The following is a description of a gene set: Human Gene Set: GSE19198_1H_VS_24H_IL21_TREATED_TCELL_DN from publication Kwon H, Thierry-Mieg D, Thierry-Mieg J, Kim HP, Oh J, Tunyaplin C, Carotta S, Donovan CE, Goldman ML, Tailor P, Ozato K, Levy DE, Nutt SL, Calame K, Leonard WJ (PMID 20064451) Interleukin-21 (IL-21) is a pleiotropic cytokine that induces expression of transcription factor BLIMP1 (encoded by Prdm1), which regulates plasma cell differentiation and T cell homeostasis. We identified an IL-21 response element downstream of Prdm1 that binds the transcription factors STAT3 and IRF4, which are required for optimal Prdm1 expression. Genome-wide ChIP-Seq mapping of STAT3- and IRF4-binding sites showed that most regions with IL-21-induced STAT3 binding also bound IRF4 in vivo, and furthermore, revealed that the noncanonical TTCnnnTAA GAS motif critical in Prdm1 was broadly used for STAT3 binding. Comparing genome-wide expression array data to binding sites revealed that most IL-21-regulated genes were associated with combined STAT3-IRF4 sites rather than pure STAT3 sites. Correspondingly, ChIP-Seq analysis of Irf4_/_ T cells showed greatly diminished STAT3 binding after IL-21 treatment, and Irf4_/_ mice showed impaired IL- 21-induced Tfh cell differentiation in vivo. These results reveal broad cooperative gene regulation by STAT3 and IRF4. Genes down-regulated in T cells treated with IL21: 1h versus 24h. studied in species Homo sapiens, and this is the list of marker genes: TUBA1A, HSD11B1, JAML, PLCB1 (NCBI Gene Id 23236), ISOC1, HMGN3, VARS1, CD48, ANXA11, PLBD1, SRSF7, SLC2A6, TBC1D9, TSPAN32, CR1, ITPRIPL1, G6PC3, PAPSS1, SLC7A11, KLHL5, TNFSF13B, RNF122, UBA7, XPO6, ROBO3, PLCD1, VILL, CD86, CABIN1 (NCBI Gene Id 26293), TUBB6, GALNT18, EMB, DDX27, FCHO1, HLA-B (NCBI Gene Id 730410), PLEK, ABCC3, ABI2, NCF2, PHPT1, HMGN2P46, FAS, NFAM1, DHRS7, TRABD2A, LILRA1, SIL1, ARAP3, MB21D2, CCL5, CYP1B1, CYTL1 (NCBI Gene Id 54360), PELP1, LITAF (lipopolysaccharide induced TNF factor), CCDC115, CYLD (CYLD lysine 63 deubiquitinase), ADAM12, TBC1D23, HBEGF, MANF, MIR3142HG, MSC-AS1, NAA25, TRAF3, NME7, FOLR3, MOB3B, BIRC3, RASGRP1, BCAR3, CARD9, CD274, ZFYVE16, CCL17, HTATIP2, SLC25A12, PEMT, GSTK1, NRROS, CD40, OCIAD1, ATP6V0D2 (ATPase H+ transporting V0 subunit d2), PPARGC1B, MICAL2, TRAF1, MSC, SRGN, OVOL1, EHF, DIAPH1, SLC25A29, CCNA1, SLC24A4 (solute carrier family 24 member 4), HK3, MELTF-AS1, PSTPIP1, SRD5A3, SLC29A3, SLC25A45, VWA8, CHST7, BTG3, MID1IP1, CD44, LY9, CCR7, ZNF711, HLA-J, LRRFIP2, LY75, CD1B, IFIH1, POLR1B, OAS2, ATP1B1, ARL6IP5, EGR2, LRRC39, NME8, BID, BMAL2, WDR74, IL2RG, ANO10, APOL3, DNAJC5B, SARDH, C1orf115, MYOF, ME1, TNFAIP6, TTYH2, SVIL, LGALS2, SLC27A3, ALDH5A1, CD83, BRPF1, NIBAN2, SPINK1, ZBTB46, LPCAT4, CYTH4, AFTPH, CDS1, RAP1GAP, VSIR, ITGAM, DIPK1A, ITGB2-AS1, SNAP23, RIPK2, METTL1, TP53I13, TRERF1, PTPRE, NR4A3, ADO, SLAMF7, SYTL1, PSME2, CBX6, MICALL2, ITGAL (NCBI Gene Id 3683), PLGRKT, AMPD2, ZGLP1, PPP1R14A, TIMP3, XAF1, MYCL, RASAL2, SEMA7A, C1orf54, CSF2RB, DNAJC4, ALG8, STARD7, C11orf21, PTGS1, SFXN4, EHD1, TMEM91, HYAL3, KYNU, PRKAG2-AS2, TOR3A, FCHSD2, TSPAN33, CDK14, PEA15, SOX4, TNFSF10, YIF1B, TAPT1, PMAIP1, FARSB, HLA-G, PDCD4, EPOP